The following is a description of a gene set: Genes predicted to be targets of miRBase v22 microRNA mmu_miR_344d_3p in miRDB v6.0 with MirTarget v4 prediction scores > 80 (high confidence targets). studied in species Mus musculus from publication Chen Y, Wang X (PMID 31504780) Mouse Gene Set: MIR_344D_3P, and this is the list of marker genes: Plpp3, Lmtk2, Pdpk1, Naa15, Rgmb, Ermp1, Sp4, Fgfr1op2, Ptpn21, Zfp712, Gpr155, Cdk13, Nxpe3, Cdk17, Med12, Slc37a1, Adcyap1, Wnt5b, Bmper, Tmem108, Plxna2, Zbtb41, Pde4b, Htr5a, Rreb1 (NCBI Gene Id 68750), Wapl, Socs4, Map2, Usp33, Tbx4, Nmt1, Wdr82, Spin4, Tnfsf11, Creb5, Adm, Nexmif, Wnt3, Trappc3, Rhag, Cldn10 (claudin 10), Gpr160, Cacnb2, Prkar2b, Golm2 (NCBI Gene Id 319996), Stard13, Cdk14, Ezr, Btf3l4, AI593442, Rp2, Irak3, Arid2, Tent5a, Serbp1, Klf6, Gad1 (NCBI Gene Id 228010), Vegfa, Gabpb2, Pde4d, Mab21l1, Fancf, Zfp800, Rere, Arid5b, Magi3, Boc, Chic2, Slc25a42, Atp8b2, Zfx, Pdzrn4, Slc6a14, Caps2, Osbpl6, Fchsd2, Sh3glb1, Kat6a, Slit3, Pcsk5, Taf7, Aff4 (NCBI Gene Id 93736), Sepsecs, Fgf12, Lrp6, Erbin, Rnf138, Pappa2, Ppp1r2, Tent4a, Zfp644, Pgm2l1, Nppc, Cpeb4, Slc8a1, 2010106E10Rik, Mfn1, St8sia4, Srsf11, Itga2, Hipk3, Sp3, B3glct, Ldlrad3, Blzf1, Dock9, Smad6, Dnal4, Trpc5os, Styx, Ptbp3, C9orf72, Prrx1, Tcf7l2 (NCBI Gene Id 21416), Armc8, Hivep1, Pclaf, Rc3h2, Rora, Vps26c, Htr1f, Nr3c1, Stk4, Cnr1, D16Ertd472e, Sub1, Hnf4g, Orc6 (origin recognition complex, subunit 6), Tmx3, Dlg3, Rasef, Gucy1a2, Ndfip2, Myh9, Ddit4l, Exoc6, Smc2, Cd9, Pcnx1, Osbpl3 (NCBI Gene Id 77147), Smad7, Fmr1, Ets1, Hace1, Fut9, Hook3, Zbtb34, Tex14, Oxr1, Zswim6, Sdr42e1, 4921517D22Rik, Otx2, F11r, Clec4d, Skil (SKI-like), Eml1, Ripor2, Ero1a, Bmpr2, Pabpc4l, Baz2b, Pcdhb17, Cdh11, Tbx5, Prkaa1, Lcorl, Zeb2, Gfpt1, Pik3ip1, Frzb, Tec, Pbrm1, Med13, Gosr1, Ahr, Cobll1, Tmem106b, Vat1l, Epb41l2, Erg, Kirrel1, Pla2g4a, Numb, Pcdh8, Sema3e, Prr11, Dcdc2a, Jrkl, Homer1, Rock2, Cbfb, Rc3h1, Ppp6r1, Usp25, AI182371, Chml, Wdr44, Kdm6a, Ppfibp1, Smarca1, Nrde2, Msi2, Zbtb44, Pip5k1b, Lrp11, Spink11